The following is a description of a gene set: Human Gene Set: DESCARTES_FETAL_MUSCLE_SKELETAL_MUSCLE_CELLS The gene expression program underlying the specification of human cell types is of fundamental interest. The study authors generated human cell atlases of gene expression and chromatin accessibility in fetal tissues. For gene expression, the study authors applied three-level combinatorial indexing to >110 samples representing 15 organs, ultimately profiling ~4 million single cells. The study authors leveraged the literature and other atlases to identify and annotate hundreds of cell types and subtypes, both within and across tissues. Our analyses focused on organ-specific specializations of broadly distributed cell types (such as blood, endothelial, and epithelial), sites of fetal erythropoiesis (which notably included the adrenal gland), and integration with mouse developmental atlases (such as conserved specification of blood cells). These data represent a rich resource for the exploration of in vivo human gene expression in diverse tissues and cell types. Marker genes curated from the annotated cluster as represented in the Descartes Human Gene Expression During Development database. from publication Cao J, O'Day DR, Pliner HA, Kingsley PD, Deng M, Daza RM, Zager MA, Aldinger KA, Blecher-Gonen R, Zhang F, Spielmann M, Palis J, Doherty D, Steemers FJ, Glass IA, Trapnell C, Shendure J (PMID 33184181) species: Homo sapiens, and this is the list of marker genes: GJD4 (NCBI Gene Id 219770), TPM1, LINP1, MB, CAPN3, C10orf71, MYBPC1, PDE4DIPP1, PLEKHG7, SLC24A2, IL17B, PHKG1 (phosphorylase kinase catalytic subunit gamma 1), TNNT3, LINC01124, PACSIN3, GJD2, HCN1, WNT4, ENSG00000251081, ENSG00000234352, PRR16, AK1, TECRL, HOMER3-AS1, SLC5A1, RPL32P13, TXLNB (NCBI Gene Id 353506), ARHGAP36, CA3, MYH8, TRIM54, ADCY2, BIN1, RRAGD, DNAJC5B (DnaJ heat shock protein family (Hsp40) member C5 beta), NEFM, ASB4, FOLR1 (folate receptor alpha), ONECUT2, PVALB, RPL7P3, SHISA2, ENSG00000256615, LCN8, LINC02421, UGT3A1, MYOZ1, PIEZO1P2, RPS7P8, PPP1R3C, MYBPC2, ACTA1, CA14, TTN, SGCG, ENO3, LINC01982, CDHR5, LRRC56, SMTNL1, TNNI2, TTC39A, MYOM3-AS1, MYH2, PRKAA2, CYP2J2, PRR32 (NCBI Gene Id 100130613), DHRS7C, KLHL40, SMTNL2, MYL4, TNNI1, ENSG00000259754, PRSS56, SYPL2, KLHL31, LMOD3, LINC01854, MYL1, MYOM3 (myomesin 3), CACNG1 (calcium voltage-gated channel auxiliary subunit gamma 1), CKMT2, LINC00570, METTL21C, MYH3, SNAI3, PPP1R3B-DT, TNPO1-DT, PPP1R27, LRTM1, CLDN10, LDB3, LINC01208, XIRP1, MAP4K1-AS1, PGAM2, IGFL4, RBM38-AS1, HSPB8, GPD1, IL20RA, ACTN2, PGPEP1L, ASB10 (NCBI Gene Id 2726), PRKAG3, MGC27382, MYOZ2 (NCBI Gene Id 53348), UFL1-AS1, HOPX, ASB15, LINC01885, NNAT, PTGFR, MYBPH, SRL, TCEAL7, C7orf33, ASB5, ATP1B4, NMRK2, HRAT17 (NCBI Gene Id 101928036), CKM, UNC45B, CFL2, HJV, SYNPO2L, ACTC1, ACTN3, FBXO40, MEG9 (maternally expressed 9), FHL1, HSPB2, KLHL30, MYL11 (NCBI Gene Id 29972), KCNJ5-AS1 (NCBI Gene Id 219833), FAM81B, SRPK3, LINC01497, TRIM7, ASB15-AS1, VMO1, KLHL41, KCNQ4, KBTBD13, FAM47E-STBD1, CMYA5, C1orf105, SP5, LINC00499, CAV3, ATP2A1, DPYSL5, TNNT2, SMPX, ENSG00000234132, ENSG00000222095, KCNK17, KCNJ6, NEB, JPH1, KCNA7, CARNS1, FBP2, C3orf52, SPHKAP, OBSCN, EEF1A2, CCNB3, SPAG6, LRRC46, MRLN, CASQ1, TPM2, TMEM38A, SMYD1, CLDN9, GADL1, ITGB1BP2, LTK, GAD3P, FAM230G, TMEM182, LINC00578 (NCBI Gene Id 100508527), DES, CA3-AS1, PPDPFL, TNNC2 (troponin C2, fast skeletal type), MYL5, COL22A1, C14orf180, LRRC38 (NCBI Gene Id 126755), CACNB1, CASC18, AGL, RPRM, SLC9A2, CACNA1S, LINC00382, LDHD, C19orf81, LINC00457, MAPK4, GSG1, MLIP-AS1, CACNG6, FER1L5, PFKM, KRT80, ARX, TRIM63, CAPN1-AS1, FGF6, TRDN-AS1, GPR37, GJD2-DT, SLN, LINC00856, ASB12, VAX2, HSPB3, ENSG00000265751, PLAAT1, TTN-AS1, ADPRHL1, MIR133A1HG, PHOSPHO1, MAFA, CXCL13, LINC01201, TMEM52, NRAP, STPG2-AS1, LINC01996, LANCL1-AS1, MYADML2, RPL3L, ASIC4-AS1, KLF5, SLC8A3, ENSG00000251574, ABRA, ANKRD1, MYPN, WFDC21P, LINC02523, ASB18, CAVIN4, LINC01209, HSPB6, FGFRL1, CCDC54-AS1, CAMK2A, DDN, EPCIP, TRIM55, VWA5A, NT5ELP